The following is a description of a gene set: studied in species Homo sapiens Human Gene Set: WP_FACTORS_AND_PATHWAYS_AFFECTING_INSULINLIKE_GROWTH_FACTOR_IGF1AKT_SIGNALING Factors and pathways affecting insulin-like growth factor (IGF1)-Akt signaling, and this is the list of marker genes: PRKAB1, MSTN, PIK3CG, IGFBP5, NEB, ITGB1, PTEN, EIF4E, DEPTOR, EIF2B2, FBXO32, GSK3B, ILK, SMAD3, TRIM63, WASL, AKT1S1, MAPKAP1, IGF1, PLD1, RPTOR, RICTOR, PDK1, TNFRSF1A, ACVR2B, AKT1, MTOR, NFKB1, RPS6KB1, MLST8, SMAD2, PPARGC1A, TNFSF9 (TNF superfamily member 9), IRS1, IGF1R, MAP1LC3A